The following is a description of a gene set: Human Gene Set: GOBP_PROTEIN_INSERTION_INTO_MITOCHONDRIAL_INNER_MEMBRANE The processes mediating the insertion of proteins into the mitochondrial inner membrane. Mitochondrial inner membrane proteins can get inserted from the cytosol, by crossing the outer membrane and being guided by an inner membrane translocase complex into their final destination in the inner membrane. Some proteins present in the intermembrane space can get inserted into the inner mitochondrial membrane. Finally, some proteins are inserted into the inner membrane from the matrix side of the membrane. species: Homo sapiens, and this is the list of marker genes: TOMM70, AGK, TIMM22, TIMM10, TIMM9, ROMO1, TIMM8B, NDUFA13, TIMM10B, TIMM29 (translocase of inner mitochondrial membrane 29), TIMM13, TIMM8A (NCBI Gene Id 84782), TRMT10B